The following is a description of a gene set: Any process that activates or increases the frequency, rate or extent of myeloid cell differentiation. studied in species Mus musculus Mouse Gene Set: GOBP_POSITIVE_REGULATION_OF_MYELOID_CELL_DIFFERENTIATION, and this is the list of marker genes: Slc9b2, Nedd9, Acin1, Mpl (myeloproliferative leukemia virus oncogene), Tgfb1, Mturn (maturin, neural progenitor differentiation regulator homolog (Xenopus)), Ppp3ca, Ripk1, Gpr68, Hmgb2, Il3, Car2, Jag1, Ror2, Med1, Il23a, Rb1, Gata2, Lif, Tnfrsf11a, Asxl2, Cd101, Id2 (inhibitor of DNA binding 2), Kdm1a, Scin, Fam210b, Stat1 (NCBI Gene Id 98183), Il34, Hspa1b, Tyrobp, Creb1, Ankrd54, Pithd1, Ccl9, Acvr2a, Inpp5d, Cd74, Csf1, Traf6, Ctnnbip1, Prkca, Hsf1, Klf10, Lef1, Itgam, Mir223, Tnfsf11, Tesc, Evi2, Fadd (NCBI Gene Id 14082), Il12b, Brd1, Runx1, Ccr1l1, Csf1r, Hif1a, Pou4f1 (NCBI Gene Id 78006), Gfi1b, Il5, Il17a, Stat5a, Tal1 (T cell acute lymphocytic leukemia 1), Glul, Stat3, Abcb10, Tescl, Stat5b, Isg15, Dcstamp, Ets1 (NCBI Gene Id 330916), Foxo3, Tmem64, Gata1, Casp8 (caspase 8), Hcls1, Tnf, Ccr1, Ocstamp, Gnas, Ppargc1b, Pou4f2, Il20, Evi2b, Ninj1, Ifng, Faxdc2, Mapk14, Eeig1, Thpo, Hax1, Ccl5, Prmt1, Rcor1, Kitl, Ccl3, Nckap1l, Trib1, Csf3, Hoxa5, Jun, Inhba, Cd4, Zfp36l1, Notch2, Itgb3, Rab7b (NCBI Gene Id 319567), Prkdc, Gsk3b, Ikzf1, Trem2, Fos, Kat7 (K(lysine) acetyltransferase 7, NCBI Gene Id 217127), Acvr1b, Dlk1, Smap1, Fes, Hmgb1, Rptor (NCBI Gene Id 74370), Pla2g3 (phospholipase A2, group III)